The following is a description of a gene set: from publication Berenjeno IM, Núñez F, Bustelo XR (PMID 17213802) Human Gene Set: BERENJENO_TRANSFORMED_BY_RHOA_UP species: Mus musculus We have used microarray technology to identify the transcriptional targets of Rho subfamily guanosine 5'-triphosphate (GTP)ases in NIH3T3 cells. This analysis indicated that murine fibroblasts transformed by these proteins show similar transcriptomal profiles. Functional annotation of the regulated genes indicate that Rho subfamily GTPases target a wide spectrum of functions, although loci encoding proteins linked to proliferation and DNA synthesis/transcription are upregulated preferentially. Rho proteins promote four main networks of interacting proteins nucleated around E2F, c-Jun, c-Myc and p53. Of those, E2F, c-Jun and c-Myc are essential for the maintenance of cell transformation. Inhibition of Rock, one of the main Rho GTPase targets, leads to small changes in the transcriptome of Rho-transformed cells. Rock inhibition decreases c-myc gene expression without affecting the E2F and c-Jun pathways. Loss-of-function studies demonstrate that c-Myc is important for the blockage of cell-contact inhibition rather than for promoting the proliferation of Rho-transformed cells. However, c-Myc overexpression does not bypass the inhibition of cell transformation induced by Rock blockage, indicating that c-Myc is essential, but not sufficient, for Rock-dependent transformation. These results reveal the complexity of the genetic program orchestrated by the Rho subfamily and pinpoint protein networks that mediate different aspects of the malignant phenotype of Rho-transformed cells. Genes up-regulated in NIH3T3 cells (fibroblasts) transformed by expression of contitutively active (Q63L) form of RHOA off plasmid vector., and this is the list of marker genes: SQOR, NGEF, DIPK2A, CD93, TOMM70, TRIP13, RAN, GMNN, HSPH1, PRIM2 (DNA primase subunit 2), SEPHS2, RPA1, PROCR, RRS1, RABGGTB, PFKL, TOP2A, TTK, EREG, GTSE1, POLR2E, NSMCE4A, INHBA, SLC66A3, PVR, RBL1, UBA2, FOXM1, RFC4, RCC1, TCERG1, TUBG1, DUSP1, HAUS3, DNPH1, THBD, FIGNL1, PSMC2, FEZ2, SORBS1, CTPS1, CCL7, EZH2, DPYSL3, MAPK6, RRM1, RFC5, NR4A1, NOP2, SRM, FOXC2, MCM2 (minichromosome maintenance complex component 2), HIVEP2, HSPA4L, EBNA1BP2, ZFAND2A, ANXA3, E2F8, FAM162A, TMEM176B, PKP4, SNRPD3, NXT1, C6orf136, ORC1, USP14, CCND1, SLBP, IRGM, ACOT9, SLC2A1, SPDL1, HSPA14, NDUFAF4, MYBL2, DNA2, RNPS1, TPI1, ERRFI1, TYRO3, LIN9, LSM3, TOPBP1, GJA1 (gap junction protein alpha 1), HSP90AA1 (heat shock protein 90 alpha family class A member 1), PRDX6, PRC1, EIF3J, CCNG1, NUP54, BNC1, MRPS10, SERPINE1, SLC35D1, UTP18, SNRNP40, TCF19, PSMA1, AK4, NID1, FKBP4, HMGN5, MCM7, EIF3B, GCLM, HAS2, PSMD11, BOP1, MSH2 (mutS homolog 2), NUBP1, FLNB (NCBI Gene Id 8413), CHEK1, RRP12, PBX3 (PBX homeobox 3), RPL32, DHRS7B, HASPIN, CHAF1B, FHL1, LRRC59, MTMR10, NUP85, GSTO1, CINP, ZFPM2, UCK2, KLF4, COQ7, CDCA5, ABCE1, MRPL34, ACKR3, PKIA (NCBI Gene Id 5569), CENPA, RUNX1, CAVIN2, ORC6, TNC, MDM2, PTGER4, AURKB, BPGM, KIF22, PPP1R14B, NUDCD2, PTGES3, KIFC1, RAD51AP1, PLA2G4A, EIF6, TUBB6, PTPRE, IER3, CCNB1, KIF2C, LIG1, UCHL5, HIGD1A, FTSJ3 (NCBI Gene Id 54803), CXCL6, EZR, TNNT2, STMN1, RRN3, CDC6, CAPG, HELLS, LDHA, PHTF2, PLK2, PTCD3, ACTG2, CCL2, PHLDA1 (pleckstrin homology like domain family A member 1), PSMB5 (proteasome 20S subunit beta 5), PON2, HPF1 (histone PARylation factor 1), RAD51, TACC3, PFDN6, CCNF, DCK (deoxycytidine kinase), SAE1, CASP8AP2, UHRF1, NHP2, TNFAIP3, DHFR, NASP, DNMT1, RPF2, DDX21, MYC, DNAJC9, LATS2, NOP16, CENPV, CIP2A, TMSB4X, TAGLN, SPECC1, IFIT2, ADORA2B, SLCO3A1, CSE1L, RANBP1, MRPL16, ZFTRAF1, LY75, DUSP6, NFKBIZ, LBHD1, NEDD4L, PIGA, CDKN1A, BDNF, RAET1E, GRWD1, CBX5, NEK2, IL1RL1, FRAT2, EFNB2, DTYMK, GRK6, PNO1, HSPD1, RBMX, NAA15, POLA1, CKS1B, PSMD13, KPNA2, C9orf40, CDC20, NR1D2, RBM38, SCHIP1, MSN, ASF1B, PPA1, CKS2, POLD1, UBE2T, MACROH2A1, DIAPH1, PHF5A, KPNB1, IPO5, IFRD2, BAX, MSLN, HBEGF, LRRC8C, TSR1, CSNK2A2, IGFBP6, EIF2S1 (NCBI Gene Id 1965), SF3A3, PGAM1, KIF20A, WDHD1, ITGA6, COL8A1, DUSP9, BUB3, ABCF2, TXNRD1, WDR43, TRIM59, USP1, POLR1E, IVNS1ABP, PLEKHA1, GAR1, ATP1B3, ACTN1, PPID, SNRPA1, PCID2, ARL4C, HPRT1, IPO7, SNRPD1, NECTIN2 (nectin cell adhesion molecule 2), H2AC8, ARL14EP, COX17, TTC27, MCM10, NUP50, ACTA1, MIS18BP1, HSPA4, HAT1, KIF11, SAP30, HK2, CDR2, AIMP2, NUSAP1, CDCA7, LBR, CDK1, PPRC1, DLGAP5, C4orf3, CDC34 (NCBI Gene Id 997), EIF2B2, TAF1D, ELL2, HMGB2, TOM1L1, SRSF1, XPO1, SPP1, GGCT, ADM, TMEM176A, GAPDH, CDC7, RPRD1B, GREM2, NGF, RUVBL2, PDLIM1, USP10, AURKA, SMC4, TBL3 (transducin beta like 3), LSM2, ADAM12, CYCS, NPNT, MRPL12, BCAT1 (branched chain amino acid transaminase 1), TIMP1, TMPO, NMT1, MYCN, CYTIP, TXN, MCM3, TIMM23, HLA-B, SF3B5, HTRA1, BTG3, PHLDB2, CCN2, POLR3K, CHD1, RACGAP1, JUN, G6PD, NET1, NCBP1, ZNF415, ESF1, NFKBIA, EED, GART, RPP30, PCNA, MAD2L1, IPO11, VARS1, LRRFIP1, THY1, DCTPP1, CASP3, TAMM41, CDC25C, EMG1, MCM4, MRPL18, PSMB3, ECT2, CCNA2, ETF1, GADD45A, CIB1, ZNRF2, EI24, FKBP2, TIMELESS, FAM110A, E2F1, RNASEH2A, RCL1, MTHFD2, LAMC2, PHC2, SS18, MRPS22, STIP1, NUP93, PTTG1, HAUS6, GDNF, GSR, MKI67, TNK2, KCNK2, KIF23, FAM171A1, EXO1, TDP2, CDCA8, PGK1, IQGAP3, SMOC1, GPC1, ALYREF, NUP62, DNAJC2, MRTO4, BIRC5, BRCA1, CKAP2, CDK8, TARDBP, TYMS, CCT7, RFLNB, SUZ12, PTGS2, SMC2, RBM14, GRPEL2, PIMREG, ACTL6A, RFC3, CHRNB1, TIPIN, GK, BUB1, CFL2, RETREG1, MAK16, ACSL5, RANGRF, TRAF3, ANAPC15, FAM136A, NPPB (natriuretic peptide B), TOMM40, GPD2, NDE1, VEGFA, THBS1, HARS1, FBL, AQP1, CCN1, NME1, SOD2 (NCBI Gene Id 79099), FOSL1, DDX18, CDCA7L, SLC35E4, CACYBP (calcyclin binding protein), YBX3, DTL, IGF2, RSL1D1, ALCAM, TP53, UTP4, AHCY, SLC30A4, TMEM97, LIN7C, PUM3, PLK4, MRPS25, CD44, SINHCAF, CCT3, ANLN, CMTR2, BANF1, GPN1, PLSCR1, ACOT7, IFRD1, PLAUR, PMF1, FEN1, SLC11A2, RANGAP1, NSUN2, KIF4A, PSMA7, DEK, TK1, CDC45, PA2G4, ACTN4, GET3, CLCN3, TAGLN2, TIMM8A, SSRP1, PCLAF, PRIM1, SLC4A4, TPGS2, SLK, LSM4, ESD, TFDP1, HMGA2, VRK1 (NCBI Gene Id 7443), EPHA2, CBX1, MCM5, ASPM, H2AZ1, PSAT1, DIAPH3, TALDO1, BOLA2, TFRC, POLA2, LSM8, GBE1, RNASEH2C, NOP58, ANKRD1, CDCA4 (cell division cycle associated 4), DNAJC21, PNPT1, RARS1, TES, NUP107, SNRPD2, OTUD4, CD151, HMGB3, POLE2, GSDME, CISD1, CORO1C, ODC1, TGIF1, INCENP, SHMT1, CSTF2, BYSL